The following is a description of a gene set: Cluster 1: genes whose up-regulation peaked one day after knockdown of OPN by RNAi in the NIH3T3 cells (fibroblasts) transformed by activated HRAS. Human Gene Set: TERAMOTO_OPN_TARGETS_CLUSTER_1 studied in species Mus musculus from publication Teramoto H, Castellone MD, Malek RL, Letwin N, Frank B, Gutkind JS, Lee NH (PMID 15516973) Activated forms of Ras family members are prevalent in many cancers where Ras mutants transduce signals essential for transformation, angiogenesis, invasion and metastasis. As a cancer progression model, we used NIH3T3 cells to explore the mechanism of Ras-induced tumorigenesis. Ras family mutants H-RasV12 and Rit79L strongly induced foci formation, while Rho family mutants RhoA-QL, Rac1-QL and Cdc42-QL were less effective. A comparison of downstream transcriptional targets of Ras and Rho family members using a 26 383 element cDNA microarray revealed that the osteopontin (OPN) gene exhibited the best correlation between magnitude of gene expression change and level of foci formation (r=0.96, P<0.001). In association with H-RasV12- and Rit79L-mediated transformation, foci secreted OPN protein and upregulated the OPN receptor CD44, suggesting the novel initiation of an aberrant OPN-CD44-Rac autocrine pathway. In support of this were the following observations. First, RGD-deficient OPN protein-binding activity was present in H-RasV12-transformed cells but not in control cells, and binding activity was inhibited by the CD44 blocking antibody. Second, foci formation, cell invasion and Rac activity were induced by H-RasV12 and inhibited by the CD44 blocking antibody. Third, foci formation by H-RasV12 was substantially reduced by a short interfering RNA (siRNA) specifically targeting OPN expression for knockdown. Fourth, H-RasV12-mediated transformation was not blocked by the GRGDS peptide, suggesting that OPN effects were not mediated by the integrins. Lastly, OPN knockdown affected the downstream expression of 160 '2nd tier' genes, and at least a subset of these genes appears to be involved in transformation. Indeed, four genes were selected for knockdown, each resulting in a disruption of foci formation and/or invasion. These results underscore the role of aberrant autocrine signaling and transcriptional networking during tumorigenesis., and this is the list of marker genes: ERBB3, GFOD2, TMEM50B (NCBI Gene Id 757), HMGCR, LSS, TFRC, DCLK3, SC5D, FMR1NB, IDH1, INSIG1, ACTL6B, BNIP3, PLCD3